Given this list of marker genes TNF, MIR143, RGS16, KLF2, MIR150, ERBB4, MIR126, MIR146A, MYB, PRL, CXCL12, here is a description of the gene set: studied in species Homo sapiens EV release from cardiac cells and their functional effects Human Gene Set: WP_EV_RELEASE_FROM_CARDIAC_CELLS_AND_THEIR_FUNCTIONAL_EFFECTS